Given this list of marker genes DLGAP5, ETS1, LAT2, HJURP, CCNE2 (cyclin E2), GOLT1A, CENPA, ADORA2B (adenosine A2b receptor), ACOX2, TUSC1, NCAPG, NGF, TCHP, KIF2C, SHCBP1, PHLDA2, SLCO2A1, IVD, KNSTRN, MAFF, CENPF, CCNB1, RFC4, NEDD4L, LAMB3, EPHA2, CCNB2, RRM1, RIOK1, MCM5, SIPA1L3, TPX2, CEP55, MMP1, MTFR2, HPCAL1, PBK, CKAP2, DTL, SYNE3, PRMT5, WDR5, MAP7, WDR3, NCAPD2, KIF11, ORC6, BLM, GCGR, PDLIM2, AURKB, MARCHF4, INAFM2, AURKA, PRC1, DYSF, PMEPA1, STIL (STIL centriolar assembly protein), RACGAP1, CALB2, CTNNAL1, RTEL1 (regulator of telomere elongation helicase 1), PDSS1 (NCBI Gene Id 23590), CCNA2, NUSAP1, ARHGAP11A, MCM4, KHDRBS3, PRIM1, POLQ, EBNA1BP2, KIF20B, here is a description of the gene set: from publication Furukawa T, Kanai N, Shiwaku HO, Soga N, Uehara A, Horii A (PMID 16532023) DUSP6/MKP-3, a specific inhibitor of MAPK1/ERK2, frequently loses its expression in primary pancreatic cancer tissues. This evidence suggests that constitutive activation of MAPK1 synergistically induced by frequent mutation of KRAS2 and the loss of function of DUSP6 plays key roles in pancreatic carcinogenesis and progression. By profiling of gene expressions associated with downregulation of MAPK1 induced by exogenous overexpression of DUSP6 in pancreatic cancer cells, we found that AURKA/STK15, the gene encoding Aurora-A kinase, which plays key roles in cellular mitosis, was among the downregulated genes along with its related genes, which included AURKB, TPX2 and CENPA. An association of expression and promoter activity of AURKA with MAPK activity was verified. Knockdown of ETS2 resulted in a reduction of AURKA expression. These results indicate that AURKA is a direct target of the MAPK pathway and that its overexpression in pancreatic cancer is induced by hyperactivation of the pathway, at least via ETS2. species: Homo sapiens Human Gene Set: FURUKAWA_DUSP6_TARGETS_PCI35_DN Genes down-regulated in PCI-35 cells (pancreatic cancer, lack endogenous DUSP6) upon expression of DUSP6 off an adenoviral vector.